The following is a description of a gene set: Depending upon the stimulus and cell type mitogen-activated protein kinases (MAPK) signaling pathway can transmit signals to regulate many different biological processes by virtue of their ability to target multiple effector proteins (Kyriakis JM & Avruch J 2012; Yoon and Seger 2006; Shaul YD & Seger R 2007; Arthur JS & Ley SC 2013). In particular, the extracellular signal-regulated kinases MAPK3(ERK1) and MAPK1 (ERK2) are involved in diverse cellular processes such as proliferation, differentiation, regulation of inflammatory responses, cytoskeletal remodeling, cell motility and invasion through the increase of matrix metalloproteinase production (Viala E & Pouyssegur J 2004; Hsu MC et al. 2006; Dawson CW et al.2008; Kuriakose T et al. 2014).The canonical RAF:MAP2K:MAPK1/3 cascade is stimulated by various extracellular stimuli including hormones, cytokines, growth factors, heat shock and UV irradiation triggering the GEF-mediated activation of RAS at the plasma membrane and leading to the activation of the RAF MAP3 kinases. However, many physiological and pathological stimuli have been found to activate MAPK1/3 independently of RAF and RAS (Dawson CW et al. 2008; Wang J et al. 2009; Kuriakose T et al. 2014). For example, AMP-activated protein kinase (AMPK), but not RAF1, was reported to regulate MAP2K1/2 and MAPK1/3 (MEK and ERK) activation in rat hepatoma H4IIE and human erythroleukemia K562 cells in response to autophagy stimuli (Wang J et al. 2009). Tumor progression locus 2 (TPL2, also known as MAP3K8 and COT) is another MAP3 kinase which promotes MAPK1/3 (ERK)-regulated immune responses downstream of toll-like receptors (TLR), TNF receptor and IL1beta signaling pathways (Gantke T et al. 2011).<p>In response to stimuli the cell surface receptors transmit signals inducing MAP3 kinases, e.g., TPL2, MEKK1, which in turn phosphorylate MAP2Ks (MEK1/2). MAP2K then phosphorylate and activate the MAPK1/3 (ERK1 and ERK2 MAPKs). Activated MAPK1/3 phosphorylate and regulate the activities of an ever growing pool of substrates that are estimated to comprise over 160 proteins. The majority of ERK substrates are nuclear proteins, but others are found in the cytoplasm and other organelles. Activated MAPK1/3 can translocate to the nucleus, where they phosphorylate and regulate various transcription factors, such as Ets family transcription factors (e.g., ELK1), ultimately leading to changes in gene expression (Zuber J et al. 2000). Reactome Pathway: RAF-independent MAPK1/3 activation species: Homo sapiens part of: MAPK1/MAPK3 signaling, and this is the list of marker genes: DUSP7, DUSP5, MAPK3, DUSP6, JAK1, DUSP9, MAPK1, TYK2, DUSP2, DUSP4, DUSP16, IL6, DUSP8, IL6R, PEA15, MAP2K1, IL6ST, DUSP1, DUSP10, MAP2K2, CDK1, PTPN11, JAK2